The following is a description of a gene set: Arthrogryposis multiplex congenita Human Gene Set: HP_ARTHROGRYPOSIS_MULTIPLEX_CONGENITA Multiple congenital contractures in different body areas. species: Homo sapiens, and this is the list of marker genes: TNNI2, PI4KA, AGRN, INS, TRIP4, GFM2, SNAP25, TRPV4, LMOD3, GBA1, KLHL40, CACNA1E, PIP5K1C, PIGS, CLCN3, ITGB4, GNPTAB, ALG3, TSEN54, ERCC1, PIEZO2, GFPT1, PLOD2, LAMA5 (NCBI Gene Id 3911), PLXND1, KLHL41, VPS33B, NUP88, KCNJ11, SYT2, COL13A1, UBA1, FKBP10, TRIP13, EXOC7, TBCD, TPM3, RIPK4, ERBB3, TPM2, CHST14, SLC25A1, EXOSC8, DSE, ZNHIT3, SLC35A3, NEB, MTRFR, REV3L, VAMP1, PPP3CA, TOR1A, LGI4, CEP55, NEK9, KIF21A, CDK5, CHRNA1, NALCN, ERCC5, ASCC1, DHCR24, MAGEL2, MYPN, EXOSC3, LZTR1, SHPK, MYO9A, VIPAS39, MUSK, SMPD4, CNTNAP1, DOK7, KAT6B, ZMPSTE24, CHMP1A, GBE1, MYOD1, PDX1, SLC5A7, RAPSN, AGTPBP1, CHAT, ABCC8, FAM20C, ZNF335, BICD2, SOX10 (SRY-box transcription factor 10), ZBTB42, MYBPC1, SCYL2, GLE1, EXOSC9, RFT1, FBN2, STAC3, ERCC2, VRK1, IBA57, SLC18A3, BLTP1, OTUD5, MYH3, ADGRG6, KIF14, CFL2, LMNA, ERGIC1, KIDINS220, GCK, COL6A1, HSPG2, PLEC, GNB2, ACTA1, ERCC6, MYH8, STAT3, SYNE1, KIF5C, TUBA1A, CHRNG, CHRNE, KBTBD13, SLC25A46, ZC4H2, SLC6A9, AUTS2